The following is a description of a gene set: This event has been computationally inferred from an event that has been demonstrated in another species.<p>The inference is based on the homology mapping from PANTHER. Briefly, reactions for which all involved PhysicalEntities (in input, output and catalyst) have a mapped orthologue/paralogue (for complexes at least 75% of components must have a mapping) are inferred to the other species. Reactome Pathway: WNT mediated activation of DVL part of: TCF dependent signaling in response to WNT electronically inferred by orthology from the curated human pathway species: Mus musculus, and this is the list of marker genes: Dvl2 (NCBI Gene Id 13543), Dvl3, Csnk1e, Dvl1, Csnk2b